Given this list of marker genes Tmem33, Tmed2, Akt1, Ddrgk1, Gcn1, Atf4, Akt2, Map3k20, Hspa5, Ddit3, Akt3, Eif2s1, Oma1, Ptpn2, Abca7, Eif2ak4, Ptpn1, Dele1, Agr2, Eif2ak3, Igtp, Impact, Rpap2, Nfe2l2, Atad3a, Nck1, Nck2, Qrich1, Bok, Eif2ak1, here is a description of the gene set: species: Mus musculus The series of molecular signals generated in response to diverse stress stimuli required to restore cellular homeostasis. The core event in this pathway is the phosphorylation of eIF2 alpha by one of four members of the eIF2a kinase family (EIF2AK1/HRI, EIF2AK2/PKR, EIF2AK3/PERK and EIF2AK4/GCN2), which leads to a decrease in global protein synthesis and the induction of selected genes, including the transcription factor ATF4, that together promote cellular recovery. Mouse Gene Set: GOBP_INTEGRATED_STRESS_RESPONSE_SIGNALING